Given this list of marker genes OAS2, BAK1, CD209, RACK1, PIK3R2 (phosphoinositide-3-kinase regulatory subunit 2), IL1A, NECTIN4, TP53, STAT5A, EIF2S1, CD3E, OAS1, IL2RA, TP73, STAT2, RELA, CHUK, IL2RB, EIF3H, IKBKE (NCBI Gene Id 9641), CD46, TLR4, NFKBIA (NCBI Gene Id 4792), HSPA2, EIF2AK2, TNFAIP3, PIK3R1, RAB9A, IFNA1, EIF2AK1, PIK3CB, MSN, STAT3, MAPK8, JAK1, IFNA16, TAB2 (NCBI Gene Id 23118), IL2, CDK2, CSNK2A3, IRAK4 (NCBI Gene Id 95458), CSNK2B, IL6, HSPA8, NFKBIB, IFNA7, BAD, TLR2, RIGI, FADD, CYCS, MAP3K7, ADAR, IFNAR1, CSNK2A2, MX1, HSPA6, IFNB1, IFNA17, CDK6, HSPA1B, MAPK10, BCL2L1, IRAK1, IRF3, STAT1 (signal transducer and activator of transcription 1), BCL2 (NCBI Gene Id 596), FOS, IL2RG, CD28, IFNA10, TRAF6, CD3D, CSNK2A1, CCND2, NFKB2, TLR7, CBLB, TRADD, CCNE2, TLR9, EIF2AK4, HSPA1L, FAS, BID, APAF1, IFNA2, RCHY1, IL12A, NFKB1, FCGR2B (Fc gamma receptor IIb), IFNA5, MAPK9, IFNA8, BBC3, IRF9, TYK2, CDKN1B, IFNA6, JAK3, FASLG, IFNA4, CASP8, IKBKG (NCBI Gene Id 8517, inhibitor of nuclear factor kappa B kinase regulatory subunit gamma), STAT5B, CCND3, CASP3, IKBKB, MAVS, PIK3CD, RAB9B, TBK1, BAX, JUN, MYD88, CCND1, HSPA1A, IFNA13, PIK3CA, IFNA14, IFIH1, OAS3, PIK3R3, CLEC4M, TRAF3, IFNA21, SLAMF1, IFNAR2, IL12B, EIF2AK3, IL1B, CASP9, IRF7, CD3G, CCNE1, CDK4, here is a description of the gene set: species: Homo sapiens Human Gene Set: WP_MEASLES_VIRUS_INFECTION Measles virus infection